The following is a description of a gene set: This event has been computationally inferred from an event that has been demonstrated in another species.<p>The inference is based on the homology mapping from PANTHER. Briefly, reactions for which all involved PhysicalEntities (in input, output and catalyst) have a mapped orthologue/paralogue (for complexes at least 75% of components must have a mapping) are inferred to the other species. Reactome Pathway: RNA Polymerase III Transcription Initiation part of: RNA Polymerase III Transcription electronically inferred by orthology from the curated human pathway studied in species Mus musculus, and this is the list of marker genes: Tbp, Polr3h, Gtf3c6, Snapc3, Polr3g, Polr1c, Snapc1, Gtf3c1, Polr3c, Gtf3c5, Polr2k, Crcp, Gtf3c3, Polr2e, Bdp1, Polr3e, Polr2f, Polr3d, Pou2f1, Polr2l, Gtf3c2